Given this list of marker genes POLR2H, TMEM63A, TRAF3IP3, RPL28, ZNF148, RPL11, LTB, CTCF, SRSF3, MYD88, SYNCRIP, CHAF1A, POU4F1, IK, LMO1, SRSF8, COX7C, SAFB2, GTF2B, FTH1 (ferritin heavy chain 1), TXNL4A, PPP1R15A, STK38, CDKN1B, RABGGTB, BICD2, MCM7, POMK, SLC3A2, RPS2 (NCBI Gene Id 6187), PTGER2, RALBP1, IL2RG, GOLGA1, LRP10, HSPA9, ACO2, CD46, GSPT1, MAPK14, RIOK3, TES, PCBP2, GAPDH, ITGB1, ADGRG1, SETD1A, SYNPO, ANAPC13, EIF3K, MAN2A2, here is a description of the gene set: Genes down-regulated in peripheral blood lymphocytes (PBL) from patients with acute transplant rejection compared to those from patients with well functioning kidneys more than 1-year post transplant. A major challenge for kidney transplantation is balancing the need for immunosuppression to prevent rejection, while minimizing drug-induced toxicities. We used DNA microarrays (HG-U95Av2 GeneChips, Affymetrix) to determine gene expression profiles for kidney biopsies and peripheral blood lymphocytes (PBLs) in transplant patients including normal donor kidneys, well-functioning transplants without rejection, kidneys undergoing acute rejection, and transplants with renal dysfunction without rejection. We developed a data analysis schema based on expression signal determination, class comparison and prediction, hierarchical clustering, statistical power analysis and real-time quantitative PCR validation. We identified distinct gene expression signatures for both biopsies and PBLs that correlated significantly with each of the different classes of transplant patients. This is the most complete report to date using commercial arrays to identify unique expression signatures in transplant biopsies distinguishing acute rejection, acute dysfunction without rejection and well-functioning transplants with no rejection history. We demonstrate for the first time the successful application of high density DNA chip analysis of PBL as a diagnostic tool for transplantation. The significance of these results, if validated in a multicenter prospective trial, would be the establishment of a metric based on gene expression signatures for monitoring the immune status and immunosuppression of transplanted patients. Human Gene Set: FLECHNER_PBL_KIDNEY_TRANSPLANT_REJECTED_VS_OK_DN from publication Flechner SM, Kurian SM, Head SR, Sharp SM, Whisenant TC, Zhang J, Chismar JD, Horvath S, Mondala T, Gilmartin T, Cook DJ, Kay SA, Walker JR, Salomon DR (PMID 15307835) species: Homo sapiens